Given this list of marker genes INTS1, INTS6, EXOSC3, INTS11, EXOSC9, TOE1, INTS8, EXOSC5, INTS6L, SAGE2P, EXOSC7, EXOSC2, INTS12, INTS9, INTS14, INTS2, EXOSC8, TUT1, USB1, INTS7, INTS5, EXOSC6, SAGE1, EXOSC4, here is a description of the gene set: Human Gene Set: GOBP_SNRNA_3_END_PROCESSING studied in species Homo sapiens Any process involved in forming the mature 3' end of an snRNA molecule.